The following is a description of a gene set: Human Gene Set: MIR7109_3P Genes predicted to be targets of miRBase v22 microRNA hsa-miR-7109-3p in miRDB v6.0 with MirTarget v4 prediction scores > 80 (high confidence targets). species: Homo sapiens from publication Chen Y, Wang X (PMID 31504780), and this is the list of marker genes: CMPK1, MTHFD2, PPP1CC (NCBI Gene Id 5501), SP2, ALDH8A1, PLEKHA1, CSMD2, HHLA1, STXBP5, VPS72, ZDHHC15, ERBB3, ADAM17, KIAA1217, GLT1D1, FBXL17, PCYT2, RETSAT, DRD1, MTOR, PTPN20, PHOX2B, HHAT, PTAR1, C4orf19, ICMT, C7orf57, ROBO1 (roundabout guidance receptor 1), AQP4, RALGPS1, TOX3, PDCD2, ATP6V1E1, SMYD5, JAG1, DDX5, NECAP1, FPGT, NPEPPS, FOXN2, LRRN1, PAGE4, TXLNB, SLF2, TTBK2, PJA2, CPEB2, GJA1, PALLD, ATXN7, ANKHD1, SAR1B, DNAJC27, GPC4, DIXDC1, DZIP3, AATK, SON, ARID1B, TMEM68, HSD17B11, ELAVL2, ZNF749, PRKG1, PRRC2B, MYCT1